Given this list of marker genes Fgfr3, Fuz, Potefam3a, Lmx1a, Ccny, Nphp3, Wnk2, Lgr5, Tgfb1, Nog, Tmem88, Gsk3b, Emd, Ubr5 (NCBI Gene Id 97951), Lrrk2, Kank1, Ankrd66, Lrp4, Sox17, Tmem64, Dkkl1, Sema5a, Shisa3, Draxin, Rspo3, Trpm4, Daam2, Ccdc88c, Nkx2-5, Foxo1, Frat1, Frzb, Gsdma3, Tmem198, Thra (thyroid hormone receptor alpha), Sox2 (NCBI Gene Id 20674), Fam53b, Frmd8, Ptk7, Cby1, Adgra2, Mad2l2, Sfrp2, Amer3, Csnk1g3, Nkd1, Ddit3, Sfrp4, Mllt3, Pin1, Ctnnd1, Csnk1d, Jade1, Shisa6, Caprin2, Zbed3, Scel, Ccar2, Amer2, Fermt1, Wnt11, Rapgef1, Wnt5a, Csnk1g1, Ppm1n, Mapk14, Fgf2, Kremen1, Egr1, Cthrc1, Sostdc1, Pin1rt1, Grem1, Ctdnep1, Lgr4, Spin4, Ruvbl2, Adnp, Fgfr2, Tbx18, D1Pas1 (NCBI Gene Id 98517), Otud5, Sfrp5, Gid8, Nherf1, Nrarp, Limd1, Ruvbl1, Apc, Amfr, Pfdn5, Dact1, Ilk, Ttc21b, Notch1, Hdac1, Rnf220, Hdac2, Hhex, Dact3, Znrf3, Zeb2, Sox4, Nppa, Mdk, Usp47, Rbpj, Reck, Rnf14, Tle3 (NCBI Gene Id 70332), Isl1, Tnn, Snai2, Tmem198b, Ptpru, Stk11, Cdh1, Notum, Wwtr1, Psen1, Prdm15, Sost, Fgf10, Cdk14, Tcf7l2, Ppm1a, Fzd7, Usp34, Ift20, Wnt5b, Plekha4, Tpbgl, Wnt10b, Wnt3a, Wls, Dab2ip, Vcp, Fzd9, Peg12, Nphp4, Potefam3b, Bicc1, Csnk1e, Tle5, Gli1, Sox10, Stk4, Sulf2, Lats2, Gpc5, Dkk2, Csnk1a1, Btrc, Axin2, Tbl1xr1, Ubac2, Ube2b, Tle4, Csnk1g2, Lrrk1, Sox9, Cyld, Map3k1, Gli3, Usp8, Tle6, Tle2, Prickle1, Col1a1, Gnaq, Rspo2, Mcc (mutated in colorectal cancers), Fgf9, Rspo1, Mks1, Apc2, Lypd6, Asb15, Lmbr1l, Egf (epidermal growth factor), Ppp2r3a, Ppm1b, Siah2, Ccnyl1, Egfr, Chd8, Rps12, Sox7, Tbl1x, Scyl2, Smad3, Tmem170b, Ctnnbip1, Dkk1, Tle1, Asb3, Invs, Shh, Dab2, Foxo3, Bmal1, Nle1, Tle7 (NCBI Gene Id 102638837), Rbms3, Dlx5, Tmem9, Smad4, Lzts2 (leucine zipper, putative tumor suppressor 2), Prkn, Ctnnd2, Cav1, Wnk1, Mesp1, Gsk3a, Kpna1, Ctnnb1, Amer1, Ddx3x, Ror2, Zfp703, Src, Dkk4, Rnf146, Stk3, Eda, Cdh2, Sox13, Dapk3, Fzd6, Nfkb1, Bambi, Xiap, Ankrd6, Gpc3 (NCBI Gene Id 14734), Rspo4, Sbno1, Vps35, G3bp1, Atp6ap2, Aspm, Cdh3, Tpbg, Otulin, Tnks, App, Axin1, Gprc5b, Sfrp1, Fzd1, Tnks2, Tmem88b, Jrk (jerky), Dkk3, Ptpro, Sdhaf2, Folr1, Nkd2, Bmp2, Yap1, Apoe, Lats1, Tmem131l, Gskip, here is a description of the gene set: Mouse Gene Set: GOBP_REGULATION_OF_CANONICAL_WNT_SIGNALING_PATHWAY Any process that modulates the rate, frequency, or extent of the Wnt signaling pathway through beta-catenin, the series of molecular signals initiated by binding of a Wnt protein to a frizzled family receptor on the surface of the target cell, followed by propagation of the signal via beta-catenin, and ending with a change in transcription of target genes. species: Mus musculus